Given this list of marker genes PCCA, ACAD9, IVD, PCCB, MMUT, APP, here is a description of the gene set: species: Homo sapiens Cerebellar hemorrhage Hemorrhage into the parenchyma of the cerebellum. Human Gene Set: HP_CEREBELLAR_HEMORRHAGE